The following is a description of a gene set: studied in species Homo sapiens Human Gene Set: REACTOME_MECP2_REGULATES_TRANSCRIPTION_FACTORS MECP2 regulates transcription factors, and this is the list of marker genes: PPARG, RBFOX1, CREB1, MEF2C, MECP2